Given this list of marker genes PTGFRN, MYMX, CD9, MYOD1, BCL9, KLF5, TMEM182, MYMK, CD81 (NCBI Gene Id 975), here is a description of the gene set: The process in which a relatively unspecialized cell acquires specialized features of a myotube cell. Myotube differentiation starts with myoblast fusion and the appearance of specific cell markers (this is the cell development step). Then individual myotubes can fuse to form bigger myotubes and start to contract. This process occurs as part of the process of skeletal muscle regeneration. Myotubes are multinucleated cells that are formed when proliferating myoblasts exit the cell cycle, differentiate and fuse. Human Gene Set: GOBP_MYOTUBE_DIFFERENTIATION_INVOLVED_IN_SKELETAL_MUSCLE_REGENERATION species: Homo sapiens